Given this list of marker genes SLC25A31, SIVA1, TOMM40, MTCH1, TIMM22, STPG1, TP53, TOMM70, SLC25A46, BCL2L1, UQCC3, AFG3L2, TOMM5, TIMM13, FZD9, GSK3A, CHCHD3, MTX2, MIR29C, VDAC2, CHCHD6, OXA1L, TIMM8B, LETM1, ATF2, AP3B1, ARHGAP11B, SLC25A6, NOL3, THEM4, MTX1, IER3, CHCHD10, EYA2, TMEM102, SLC25A5, BCS1L, TOMM7 (translocase of outer mitochondrial membrane 7), BLOC1S2, TIMM10, IMMT, TIMM29, RHOT1, CIBAR1, MICOS10, ADCK1, MICOS13, OPA1, TOMM20, BAD, PPIF, GHITM, MTX3, CAMK2A, GSK3B, DNAJC11, PLSCR3, HSPA9, COX18, TOMM6, TMEM14A, LRRK2, PMAIP1, TRMT10B, APOO, PINK1, ZNF205, HIP1R, MICU1, NDUFA13, PPM1K, ATP5IF1, SLC25A4, PEX5, TIMM9, TIMM10B, APOOL, SLC9A1, RTL10, TIMM50, MUL1, MIR29A, CALM3, SAMM50, SPG7, BCL2, GCLC, CLN8, MFN2, BAX, NAIF1, ROMO1, MAIP1, BOK, TMEM126A, BNIP3L, BID (NCBI Gene Id 637), BAK1, TAFAZZIN, RHOT2, MIR17, TMEM11, MIR29B1, AGK, HSPA1A, MPV17L, BNIP3, BCL2L11, OMA1, MTCH2, ACAA2, TOMM22, STAT3, TIMM8A, HK2, MOAP1, SNCA, SLC35F6, ALKBH7, here is a description of the gene set: species: Homo sapiens A process that is carried out at the cellular level which results in the assembly, arrangement of constituent parts, or disassembly of a mitochondrial membrane, either of the lipid bilayer surrounding a mitochondrion. Human Gene Set: GOBP_MITOCHONDRIAL_MEMBRANE_ORGANIZATION